The following is a description of a gene set: Occupational exposure to nickel compounds is associated with lung cancer risk; both genotoxic and epigenetic mechanisms have been proposed. For comprehensive examination of the acute effects of nickel(II) acetate on gene expression in cultured human peripheral lung epithelial HPL1D cells, microarray analyses were carried out with cDNA chips (approximately 8000 cDNAs). Cells were exposed for 24 h to nontoxic (50, 100, and 200 microM) or toxic (400, 800, and 1600 microM) nickel(II) concentrations. Cluster analysis was applied to the genes with > or = 2-fold change at any concentration. Two main clusters showed marked up- or down-regulation at the highest, toxic concentrations. The data further subdivided into 10 highly cohesive clusters with high probability, and of these only 2 had the same response trend at low nontoxic as at high concentrations, an observation of clear relevance to the process of high- to low-dose extrapolation in risk assessment. There were genes showing > or = 2-fold change at the three lower nontoxic concentrations, those most relevant to in vivo carcinogenesis. In addition to expected responses of metallothionein, ferritin, and heat-shock proteins, the results revealed for the first time changed expression of some potential cancer-related genes in response to low-dose Ni(II): RhoA, dyskerin, interferon regulatory factor 1, RAD21 homologue, and tumor protein, translationally controlled. Overall, most of the genes impacted by nontoxic concentrations of nickel(II) acetate related to gene transcription, protein synthesis and stability, cytoskeleton, signaling, metabolism, cell membrane, and extracellular matrix. from publication Cheng RY, Zhao A, Alvord WG, Powell DA, Bare RM, Masuda A, Takahashi T, Anderson LM, Kasprzak KS (PMID 12915101) Human Gene Set: CHENG_RESPONSE_TO_NICKEL_ACETATE studied in species Homo sapiens Genes down-regulated in HPL1D cells (lung epithelium) upon exposure to nickel acetate., and this is the list of marker genes: TRAP1, GDI2, CEBPD, URGCP, HSP90AA1, PNPLA2, TCF7L2 (NCBI Gene Id 6934), USP16, ACO1, POLR2E, ACTR2, ABCC3, RBBP8, DHRSX, ST13, CSNK2B, TLK2, APP, PSMD5, TXNDC12, CLN6, GTF2A2, PI4K2B, MAP1B, HSPE1, SH3BP5-AS1, POLR2C, EIF2D, CP, ATP1B1, MS4A6A, JUN, FAIM2, LRRC37BP1, ZNF3, TIAL1, RAB1A, RNF13, SLA, FCMR, CD68, ERI3, H19, TF, RABGGTB